Given this list of marker genes KCNE3, SCN2B, KCNE5, KCNE4, KCNJ5, KCNJ8, KCNH2, KCND3, KCNJ2, KCNA5, KCNQ1, KCNE2, KCNE1, KCNJ3, here is a description of the gene set: Human Gene Set: GOMF_VOLTAGE_GATED_POTASSIUM_CHANNEL_ACTIVITY_INVOLVED_IN_CARDIAC_MUSCLE_CELL_ACTION_POTENTIAL_REPOLARIZATION Enables the transmembrane transfer of a potassium ion by a voltage-gated channel through the plasma membrane of a cardiac muscle cell contributing to the repolarization phase of an action potential. A voltage-gated channel is a channel whose open state is dependent on the voltage across the membrane in which it is embedded. studied in species Homo sapiens